Given this list of marker genes Nup88, Rps15, Riok2, Xpo1, Nop9, Npm1, Ran (NCBI Gene Id 19384), Ltv1, here is a description of the gene set: The directed movement of a ribosomal small subunit from the nucleus into the cytoplasm. Mouse Gene Set: GOBP_RIBOSOMAL_SMALL_SUBUNIT_EXPORT_FROM_NUCLEUS studied in species Mus musculus